Given this list of marker genes ARID3A, CFAP300, HSBP1P2, OR13C2, NT5C3B, TMEM176A, ADCY5, SPATA33, ILVBL, ITGAE, GPR137B, OR2AK2, LARGE1, CYBRD1, EPB41L5 (NCBI Gene Id 80242), LINGO2, KRTAP5-6, ITGAV, CASP12, PGLYRP3, OR10D4P, CYTIP (NCBI Gene Id 9595), CLEC7A, SNORD116-27, CKB, TBATA, CCNYL6, FZD3, OR8A1 (NCBI Gene Id 390275), DCDC1, MRGPRG-AS1, TLCD5, SCARNA8, TNRC6A, S100G, TFAP2D, CD38 (NCBI Gene Id 952), SUMO4, PXYLP1, UBR4, NPR2, MIR33A, CPD, IBSP, OOSP2, PKHD1L1, TRIM55, AGR2, NT5C3A, CEACAM6, KLHL14, OR5M1 (olfactory receptor family 5 subfamily M member 1), OR4C5, FAP, PTPN13, CXCR5, RAI1, PHLPP1, LINC00525, SCGB1D1 (NCBI Gene Id 86801), FRMD7, OR51H1, DHX16, OR52H1, WRAP53, SLC12A4, CDC14C, ZNF114, NCOA3, WASF2, SPATA6L, C6 (complement component 6), SNORA37, EFHB, OR51A7, ZNF879 (NCBI Gene Id 345462), GLCE, ARFGEF2, SUCLG2P2, CACUL1, CDYL, CD2BP2, EMC3-AS1, GDPD1, NLRP14, KRTAP20-1, HTT, PPM1N, TBL1X, NR1H3, ARF3, DIP2B, SLC6A20, TP53BP1, TULP4, SUCNR1, CLC, FOXJ2, LRIT3, HIPK1, SYCP2, ASB2, TNFRSF17 (TNF receptor superfamily member 17), STAT4, OR1S1, AMBRA1, ACSS3, OR5D18, OR13H1, ANOS1, SRGN, SCN8A, CA1, PIH1D2, OR9A4, LINC00301, GPR107, RNF217, WDR88, TMEM176B, OPN5, MUSTN1, SNORD115-2, ADIPOR2, SKIL (NCBI Gene Id 6498), MSTN, CNKSR2, HNRNPLL, CRTC3, SPAG9, PSMG4, TM4SF20, RNF24, CLGN (calmegin), SH3D19 (NCBI Gene Id 152503), OR6X1, POU2F1, PARD6G, GP1BA, ATP11A, DEFB110, CAMSAP1, OR51F2, OR52E6, OR51B6, TAFA1, LGMN, GLRB, BTN1A1, KRTAP4-3, LIMS1, SPAM1, REEP1, PTGR2, KCNAB3, PAGE4, GPLD1, DEFT1P, ADAM5, PSORS1C3, FAM136CP, PRKD3, SLC44A1, DUSP16 (NCBI Gene Id 80824), TCN1, SWAP70, OMD, P2RX5, HESX1, PLEKHG2, MIR376C, SCGB1D4, SMAD1, ZMYND8, CCDC88A, GPR32, RERE, IL19, NEO1, PIRT, CIBAR1P1, CPEB3, SLC11A2, IHO1, WDR25, F8 (coagulation factor VIII), SELE, DEFB133, SAP130, MFSD2B, SNORA38B, KIAA0513, OR2T8 (olfactory receptor family 2 subfamily T member 8), here is a description of the gene set: Human Gene Set: GSE32034_UNTREATED_VS_ROSIGLIZATONE_TREATED_LY6C_LOW_MONOCYTE_UP PPARγ is known for its anti-inflammatory actions in macrophages. However, which macrophage populations express PPARγ in vivo and how it regulates tissue homeostasis in the steady state and during inflammation is not completely understood. We show that lung and spleen macrophages constitutively expressed PPARγ, while other macrophage populations did not. Recruitment of monocytes to sites of inflammation was associated with induction of PPARγ as they differentiated to macrophages. Its absence in these macrophages led to failed resolution of inflammation, characterized by persistent, low-level recruitment of leukocytes. Conversely, PPARγ agonists supported an earlier cessation in leukocyte recruitment during resolution of acute inflammation and likewise suppressed monocyte recruitment to chronically inflamed atherosclerotic vessels. In the steady state, PPARγ deficiency in macrophages had no obvious impact in the spleen but profoundly altered cellular lipid homeostasis in lung macrophages. Reminiscent of pulmonary alveolar proteinosis, LysM-Cre x PPARγflox/flox mice displayed mild leukocytic inflammation in the steady-state lung and succumbed faster to mortality upon infection with S. pneumoniae. Surprisingly, this mortality was not due to overly exuberant inflammation, but instead to impaired bacterial clearance. Thus, in addition to its anti-inflammatory role in promoting resolution of inflammation, PPARγ sustains functionality in lung macrophages and thereby has a pivotal role in supporting pulmonary host defense. from publication Gautier EL, Chow A, Spanbroek R, Marcelin G, Greter M, Jakubzick C, Bogunovic M, Leboeuf M, van Rooijen N, Habenicht AJ, Merad M, Randolph GJ (PMID 22855714) species: Homo sapiens Genes up-regulated in Ly6C low monocytes: untreated versus rosiglitazone.